The following is a description of a gene set: Genes down-regulated in blood 7d vs 0hr in adults (18-45) after exposure to CN54gp140 adjuvanted with GLA-AF, time point 7D, administered i.m. from publication Anderson J, Olafsdottir TA, Kratochvil S, McKay PF, Östensson M, Persson J, Shattock RJ, Harandi AM (PMID 29535712) Human Gene Set: ANDERSON_BLOOD_CN54GP140_ADJUVANTED_WITH_GLA_AF_AGE_18_45YO_7DY_DN studied in species Homo sapiens Systems biology approaches have recently provided new insights into the mechanisms of action of human vaccines and adjuvants. Here, we investigated early transcriptional signatures induced in whole blood of healthy subjects following vaccination with a recombinant HIV-1 envelope glycoprotein subunit CN54gp140 adjuvanted with the TLR4 agonist glucopyranosyl lipid adjuvant-aqueous formulation (GLA-AF) and correlated signatures to CN54gp140-specific serum antibody responses. Fourteen healthy volunteers aged 18-45 years were immunized intramuscularly three times at 1-month intervals and whole blood samples were collected at baseline, 6 h, and 1, 3, and 7 days post first immunization. Subtle changes in the transcriptomic profiles were observed following immunization, ranging from over 300 differentially expressed genes (DEGs) at day 1 to nearly 100 DEGs at day 7 following immunization. Functional pathway analysis revealed blood transcription modules (BTMs) related to general cell cycle activation, and innate immune cell activation at early time points, as well as BTMs related to T cells and B cell activation at the later time points post-immunization. Diverse CN54gp140-specific serum antibody responses of the subjects enabled their categorization into high or low responders, at early ( < 1 month) and late (up to 6 months) time points post vaccination. BTM analyses revealed repression of modules enriched in NK cells, and the mitochondrial electron chain, in individuals with high or sustained antigen-specific antibody responses. However, low responders showed an enhancement of BTMs associated with enrichment in myeloid cells and monocytes as well as integrin cell surface interactions. Flow cytometry analysis of peripheral blood mononuclear cells obtained from the subjects revealed an enhanced frequency of CD56<sup>dim</sup> NK cells in the majority of vaccines 14 days after vaccination as compared with the baseline. These results emphasize the utility of a systems biology approach to enhance our understanding on the mechanisms of action of TLR4 adjuvanted human vaccines., and this is the list of marker genes: PAX2, PRKCZ, PDXDC1, SMPD2, NUDT16L1, UQCR10, IDH3B